The following is a description of a gene set: The process in which a fatty acid is transported across a membrane. Human Gene Set: GOBP_FATTY_ACID_TRANSMEMBRANE_TRANSPORT studied in species Homo sapiens, and this is the list of marker genes: SLC22A9, ACSL5, THBS1, ABCD1, IRS2, AKT2, ABCD4, CPT1A, ABCD3, CD36, SLC25A20, SLC2A1, SLC27A1, ACSL1, SLC27A5, CPT2, CPT1B, AKT1, ABCD2, SLC5A8